Given this list of marker genes IRF7, FBXO32, RGS18, STK26, NOSIP, ALDH16A1, NDC80, BTF3L4, ZBTB6, NOP56, WRAP73, FAM118B, ABHD13, IL10RA, CNKSR3 (CNKSR family member 3), COPS3, NCK2, LRATD2, ZNF324B, AQR, FRMD6, PARP11, CD53, ELAVL1, ANTXR2, LPAR6, BMF, BCL6 (NCBI Gene Id 604), PNP, STAT4, C1orf174, ITM2A, WLS, ADCY9, KCNJ1, RTP4, MYL11, TRIM14, PCTP, UBE2D2, TRAPPC1, RIPK3, SPAG9, ZNF143, PDXP, ESR1, GGH, PDE7A, BRWD1, SNX9, SUPT7L, DUSP4, CTSV, LPP-AS2, MRPS24, AIDA, TMC6, HDDC2, BBS10, SASH1, CAB39, AKAP12 (A-kinase anchoring protein 12), GADD45G, CA2 (NCBI Gene Id 760), STX8, CNN3, UTP6, C1GALT1, TNFAIP8L2, EIF2AK4, ARHGAP18, SASS6, STAP1, RTL6, LRRC28, DLGAP5, STOML2, ZNF608, PSMC1, CEP57L1, ALCAM, MCM5, CRY1, ZBTB8A, AMZ2, CSRP2, SMIM7, KLHL22, PLPP2, RFTN2, NAT1, STK11, AFG2A, HAT1, PSMA5, LETM1, GPAT3, SLC16A10, GOLPH3L, ARL1, TMEM86A, NINJ1, DCLRE1B, GABARAPL1, ZRANB1, DNAJA3, ABHD17A, SMAD1, UBE2F, UBE2J2, GCNT1, NIPSNAP2, PPIE (peptidylprolyl isomerase E), LIMA1, COPS4, TMEM161A, SLC35A4, SPATA6, DAXX, SPAST, CETN3, PPM1D, PRPF18, FH, METTL22, CYTH3, NTMT1, TCN2, GHDC, COP1, PPM1A, RASSF9, UQCRC1, CUX2, CIR1, FIGNL1, SYCE2, LPCAT2, INPP1, REEP5, FKBP2, NDUFB3, NUDT15, SLFN13, SDC4, PRSS12, MXI1 (NCBI Gene Id 4601), RNGTT, CRYBG1, SLC7A5, GLCCI1 (NCBI Gene Id 113263), TIMELESS, ACOT2, DGLUCY, INTS10, ALDH1B1, IRAG2, NSMCE2, TRMT10C, ELOVL7, ZNF229, WSB2, EPS8, MANF, GALNT4, GBE1, APBB1, SLC52A3, JADE1, GSTK1 (glutathione S-transferase kappa 1), ADGRE1, ZNF655, TREML2, RRM1, GRAP2 (GRB2 related adaptor protein 2), SELL, BLVRB, SLC30A4, GCH1, IFI27L2 (NCBI Gene Id 83982), TSGA10 (NCBI Gene Id 80705), MYO7A (NCBI Gene Id 4647), CEP89, SUSD1, HYPK, EXOC8, HSD11B1, TWSG1, PRPF38A, FCMR, OASL, TRAF3IP3, UGP2, TBCB, NUFIP1 (nuclear FMR1 interacting protein 1), IFNAR2, TSPAN3, INTS12 (NCBI Gene Id 57117), DHX40, UXT, here is a description of the gene set: The transcription factor FoxP3 partakes dominantly in the specification and function of FoxP3+ CD4+ T regulatory cells (Tregs), but is neither strictly necessary nor sufficient to determine the characteristic Treg transcriptional signature. Computational network inference and experimental testing assessed the contribution of several other transcription factors (TFs). Enforced expression of Helios or Xbp1 elicited specific signatures, but Eos, Irf4, Satb1, Lef1 and Gata1 elicited exactly the same outcome, synergizing with FoxP3 to activate most of the Treg signature, including key TFs, and enhancing FoxP3 occupancy at its genomic targets. Conversely, the Treg signature was robust to inactivation of any single cofactor. A redundant genetic switch thus locks-in the Treg phenotype, a model which accounts for several aspects of Treg physiology, differentiation and stability. species: Homo sapiens from publication Fu W, Ergun A, Lu T, Hill JA, Haxhinasto S, Fassett MS, Gazit R, Adoro S, Glimcher L, Chan S, Kastner P, Rossi D, Collins JJ, Mathis D, Benoist C (PMID 22961053) Genes up-regulated in T reg: XBP1 knockout versus wildtype. Human Gene Set: GSE40273_XBP1_KO_VS_WT_TREG_UP